The following is a description of a gene set: Human Gene Set: HP_ESOPHAGEAL_ATRESIA A developmental defect resulting in complete obliteration of the lumen of the esophagus such that the esophagus ends in a blind pouch rather than connecting to the stomach. Esophageal atresia studied in species Homo sapiens, and this is the list of marker genes: YY1, AR, PAH (NCBI Gene Id 5053), SOX2, FANCL, IFT80 (intraflagellar transport 80), OTX2, DYNC2H1, SIX6, WBP11, ARNT2, FANCD2, POLA1, FOXF1, DYNC2I2, PLEC, MYCN, RMRP, FANCB, SMARCD1, EFTUD2, WDR35, HESX1, FGFR1, PAICS, CHD7, FGFR2, ITGB4, ZIC3, ERCC4, PROKR2, MAMLD1, SOX3, DYNC2I1